Given this list of marker genes SLC4A9, SLC4A4, SLC4A8, SLC4A7, SLC4A5, SLC4A10, here is a description of the gene set: studied in species Homo sapiens Human Gene Set: GOMF_SODIUM_BICARBONATE_SYMPORTER_ACTIVITY Enables the transfer of a solute or solutes from one side of a membrane to the other according to the reaction: Na+(out) + HCO3-(out) = Na+(in) + HCO3-(in).